Given this list of marker genes Nr1h4, Ncoa1, Baat, Slco1a4, Slc51b, Abcc3, Fabp6, Abcb11, Alb, Slc10a1, Slc27a5 (NCBI Gene Id 26459), Slc10a2, here is a description of the gene set: Reactome Pathway: Recycling of bile acids and salts This event has been computationally inferred from an event that has been demonstrated in another species.<p>The inference is based on the homology mapping from PANTHER. Briefly, reactions for which all involved PhysicalEntities (in input, output and catalyst) have a mapped orthologue/paralogue (for complexes at least 75% of components must have a mapping) are inferred to the other species. part of: Bile acid and bile salt metabolism electronically inferred by orthology from the curated human pathway species: Mus musculus